Given this list of marker genes TAS2R5, ALDOB, DARS2, WDR46, CIAO2A, SKIC8, ADGRF5, ZNF174, NDUFAF2, BTNL9, PRXL2A, PAGE4, RUVBL2, FAM9A, LINC00276, ATAD1, CDC14B, SDF4, REN, OGFOD1, PFDN4, ENSG00000224090, PNPO, CYC1, MRPL20, NDUFB9, ALDH18A1 (aldehyde dehydrogenase 18 family member A1), PTEN, PABIR1, TPRXL, NUP50 (NCBI Gene Id 26132), NDUFB5, CASC22, C10orf143, RWDD1, MLEC, KCNU1, PABPC1L, OSER1-DT, PRR35, CCT7, CRTAC1, CHIA, FOXR1, CMC1, SHF, MRPL24, RO60, UTP20, LINC01845, AHCY, KCTD18, ANHX, CADPS, PRKCA, UQCRC2, ADPRHL1, ADGRE1, NGB, RGS22, LDAH, WDR72, PKDCC, CYSLTR1, LINC01579, METTL5, MICA, CFC1B, FAM169BP, DNAJC17, ASXL2, COA5, TRABD2B, ATP1A4, TBC1D9, HABP4, GPC4, PDSS2, MIR99AHG, NKX6-2, MEG3, SNRPE, SLC3A2, ERVMER34-1, OR51B4, ZNRF4, REM1, HOMEZ, FMO6P, CNNM2 (cyclin and CBS domain divalent metal cation transport mediator 2), THOC2, MUC19, CTSO, IRGC, GTF3C6, HS6ST2, DLX4, IGSF5, MAPK4, SPATC1, SLC35D2, SELENON, ZNF608, CCDC59, PCDHA6, UBE2G2, PHOX2A, PDAP1, LDLRAD3, TIPIN, SULT2B1, KIF9-AS1, TMEM67, SLC27A5, SMARCE1, ZNF623, ANKS6, METAP2, USP29, NME5, TMEM132A (transmembrane protein 132A), ZPBP2, TK2, DDX27, HEATR5A (NCBI Gene Id 387979), S100A7A, CSDE1, CCT4, GNGT2, MRPS31, KCNE5, PML, FAM133A, MEIS3, UNC119, NDUFAB1, POLR2H, AHCYL1, HECTD2, PCDHAC1, SEC14L1P1, TGS1, QRSL1, HRH4, ARHGEF10, TBC1D4, BOLA3, STX16, THRAP3, KDM8, ANKRD10, STOML2, TAF11, CCNB1IP1, TOMM22, SNRPC, ABCC12, ZMPSTE24, MTRES1 (mitochondrial transcription rescue factor 1), TIMM23, TXNRD2, SST, TOPBP1, RPS17P5, PLPP3, TMEM72-AS1 (NCBI Gene Id 220980), HSPA9, DEFT1P, GHSR, SLC52A2, CD320, TMEM114, EBNA1BP2, TPRG1, C2CD2, CNTN5, RPL10P17, BUD23, ZNF251 (zinc finger protein 251), TRA2B, SECISBP2, ODR4, CDC45, HOXD12, RPAIN, TBX6, MEGF6, ARHGAP33, FLJ12825, OCEL1, MCHR1 (melanin concentrating hormone receptor 1), PPL, OAZ2, ZNF7 (NCBI Gene Id 7553), AXIN2, SUV39H1, here is a description of the gene set: studied in species Homo sapiens Human Gene Set: GSE27291_0H_VS_6H_STIM_GAMMADELTA_TCELL_DN from publication Pont F, Familiades J, Déjean S, Fruchon S, Cendron D, Poupot M, Poupot R, L'faqihi-Olive F, Prade N, Ycart B, Fournié JJ (PMID 21968650) Genes down-regulated in gamma delta T cells activated by phophoantigen BrHPP and IL2: 0h versus 6h. We used microarrays to detail the global programme of gene expression by circulating TCRVgamma9+ gamma delta T cells isolated from healthy individuals,tested either as resting cells or cells activated by phosphoantigen BrHPP and IL-2at an early(+6hrs) and a late (+7days) timepoint. We find that with more “NK cell” genes than alphabeta T cells and more “T cell” genes than NK cells, the circulating TCRVgamma9+ gamma delta T cells cells have a hybrid transcriptome. The gene signature of the activated cells recapitulates their physiological functions: Th1 cytokine, chemokine and cytotoxic activities at first and mitotic activity at later time points. The gene expression pattern of activated normal gamma delta T cells is nevertheless clearly distinctive from that of NK/T and peripheral T cell lymphomas of the gamma delta subtype.